Given this list of marker genes Map2k2, Chaserr, Tgfbr1, Psen1, Slc46a2, Apc, Mad1l1, Tbx1, Gba1, Hand2, Fgf10, Asxl1, Prdx2, Pax1, Hoxa3, Mafb, Fgf3, Cited2, Pbx1, Ctc1, Carmil2, Srf, Six1, Six4, Jarid2, Myb, Foxe1, Zmpste24, Atm, Fadd, Prkdc, Coa5, Bcl2, Gata3 (NCBI Gene Id 14462), Aire, Foxi3, Bcl11b, Tyr, Abl1, Mapk1, Psen2, Ephb3, Rag1, Ripk3, Ccnb2, Adrm1, Cacnb4, Ctnnb1, Lmo4, Shh, Sco1 (NCBI Gene Id 67104), Mapk3, Foxn1, Raf1, Map2k1, Zbtb1, Hes1, Ikzf1, Nfatc3, Braf, Crkl, Bcl2l11, here is a description of the gene set: Mouse Gene Set: GOBP_THYMUS_DEVELOPMENT The process whose specific outcome is the progression of the thymus over time, from its formation to the mature structure. The thymus is a symmetric bi-lobed organ involved primarily in the differentiation of immature to mature T cells, with unique vascular, nervous, epithelial, and lymphoid cell components. studied in species Mus musculus